The following is a description of a gene set: Genes predicted to be targets of miRBase v22 microRNA hsa-miR-7110-5p in miRDB v6.0 with MirTarget v4 prediction scores > 80 (high confidence targets). from publication Chen Y, Wang X (PMID 31504780) species: Homo sapiens Human Gene Set: MIR7110_5P, and this is the list of marker genes: CETN1, TRIM58, ASIC1, ATL2, ZFR2, PTCH1, ARID3B, BANF1, NEURL1B, KLC2, ABLIM3, TBC1D30 (TBC1 domain family member 30), CREB3L1, CNPY2, CNNM1, DPY19L1, NTSR1, OLFM2, PABPC1L2B (NCBI Gene Id 647480), IQSEC2, NFIC, MEF2D, DLK1, ADGRB1, MS4A15, PRKACA (protein kinase cAMP-activated catalytic subunit alpha), PHOSPHO1, DNAJB5, B3GNT7, DOK3, PCYT1B, SLC25A4, KLF16, MYH14, RC3H1, SEMA6A, CYP2W1, CITED2, POLR2F, TNS4, PABPC1L2A, KDM6B, TLDC2, SCRT2, SPRED3, FOXO6 (NCBI Gene Id 343552), RAB1B, FOXA2, U2AF1L4, CYB5R3 (cytochrome b5 reductase 3), SOX3, COX10, SLC8A2, WDR33, CDK12, FXR2, SMARCD1, RALY, PADI2, CDC25A, CD276, HOXA9, PLVAP, RASL10B, MECP2, ZNF324, KCNIP3, EGFR, NECTIN1, FOXP4, PUS10, RPH3AL, PDF, ARHGEF1, VPS13D, GSDMA, ELAVL3, ZNF385A, DAGLA, RAB18, PSD4, CELF5, CTNS, TMEM51, SLC6A17, BCL11B, ZNF74, PRKCG, SFTPB, RPP14, EFNB1, ZSWIM4, LIN7C, HYOU1, PIN1, GRIN3A, YWHAH, MIER2 (NCBI Gene Id 54531), CNIH4, CNIH2, PPP6R1, TRH, THEMIS2, RUNX3, OTUB1, HIP1, FZD2, IDUA, TTC9, DMTN, KIAA0232, CABP2, GGA1, SEPTIN9, RSPO4, EFNA5, IGFBP5, RRP7A, RAB3A, FIZ1, ZBTB7A, ZNF512B, PIP5K1A, B4GALT7, RAB2A, HECTD3, SPNS2, LZTS3, RARA, BCL2L13, PTPRD, MNT, TRIM3, PTGES2, STRADA (NCBI Gene Id 92335), DDAH1, CTCFL, NECTIN4, MSR1, ZC3H7B, UPK2, HSD11B2, CISD3, KLF12, LHFPL1, KMT5A, TOR1A, KIF21B, KCNK3, NDFIP1, COG8, C5AR1 (NCBI Gene Id 728), CAMK2A, SYNGAP1, CDK5R2, SYT5, LEF1, DESI1, FOSL1, LIG3, GPR3 (NCBI Gene Id 2827), BSN, P2RX1, TBKBP1, IGF2, KMT2D, TPBGL (NCBI Gene Id 441617)